Given this list of marker genes SLC34A3, ORAI1, PTH, PHEX, FGF23, SPP1, ROS1, DMP1, CYP27B1, FGFR2, FAM20C, CDKN1A, ALPL, ENPP1, CYP24A1, GALNT3, NFKB2, FGFR3, CYP11B2, NFKB1, CCND1, SLC34A1, KL, here is a description of the gene set: species: Homo sapiens Human Gene Set: WP_FGF23_SIGNALING_IN_HYPOPHOSPHATEMIC_RICKETS_AND_RELATED_DISORDERS FGF23 signaling in hypophosphatemic rickets and related disorders